Given this list of marker genes DISC1, RTN4, DAB1, SRGAP2C, LAMB1, BMERB1, RELN, SUN1, SRGAP2 (SLIT-ROBO Rho GTPase activating protein 2), SYNE2, PAFAH1B1, SUN2, DAB2IP, SOCS7, P2RY12, CDK5R1, CDK5, COL3A1, LRP8, ADGRG1, MBOAT7, ZMIZ1, CDK5R2, NR2E1, GLI3, WDR47, CTNNB1, FOXG1, here is a description of the gene set: studied in species Homo sapiens Human Gene Set: GOBP_TELENCEPHALON_GLIAL_CELL_MIGRATION The orderly movement of glial cells through the telencephalon.